The following is a description of a gene set: studied in species Mus musculus Mouse Gene Set: GOMF_UBIQUITIN_LIKE_PROTEIN_LIGASE_BINDING Binding to a ubiquitin-like protein ligase, such as ubiquitin-ligase., and this is the list of marker genes: Dnm1l (NCBI Gene Id 74006), Srprb, Xbp1, Hspa8, Pcbp2, Nfkbia, Erlin1, Sorbs1, Trp53, Ccdc50 (NCBI Gene Id 70600), Chek2 (checkpoint kinase 2), Abcb1b (NCBI Gene Id 18669), Ddrgk1, Trim28, Stat1, Bag6, Cul3, Kcnq3, Tlr3, Dio2, Magea10, Usp13, Cebpb, Stub1, Ube2j1, Zfp746, Smg5, Pink1, Usp25, Pa2g4, Fbxo7, Prdx6, Ralb (NCBI Gene Id 80581), Smc6, Wrap53, Aup1, Rnf40, Dtx3l, Hspa1b, Ski, Nedd8, Smad5, Tank (NCBI Gene Id 97021), Faf2, Atxn3, Jak1 (NCBI Gene Id 319959), Syt11, Egr2, Limk1, Cul5, Tcp1, Foxo1, Trib2, Smad3, Tpi1, Grk2, Ptk2b, Prkacb, H13, Rangap1, Hgs, Traf1, Trib1, Arih1, H2bc23, Ube2c, Trip4, Pax6, Det1, Ubash3b, Jun, Ankra2, Ubc, Ltbr, Ube2l3, Ptprn (NCBI Gene Id 19275), Tsg101, Nploc4, Slc25a5, Ambra1, Spop, Magea5, Rala, Brca1, Ggn, Rb1 (NCBI Gene Id 19645), Scn5a, Trib3, Ube2w, Laptm4b, Abcb1a, Bcl10, Cul7, Myc, Pias4, Vcl, Casc3, Rpl11, Traf4, Casp8, Hsp90ab1, Usp9x, Sipa1l1, Tdpoz2, Rps27a, Ubb, Erbb2, Uchl1, Rpl23, Pml, Pdlim2, Parp1, Gabarapl1, Rigi, Prr7, Tdpoz5, Fate1, Ccnb1-ps, Mdm2, Rpl5, Ube2a, Spopl, Cul2, Ywhae, Uqcrc1, Rad18, Sncaip, Spopfm2, Rhobtb3, Ube2g1, Bok, Prdx6b, Tubb5, Cxcr4, Mid1, Hif1a, Per3, Atp6v0c, Smad6, Rffl, Ifi204, Map1lc3a, Bag5, Rnf8, Cdk5rap3, Gpi1, Rnf31, Smad1, Sting1 (NCBI Gene Id 72512), Sh3kbp1 (NCBI Gene Id 80469), Becn1, Uba52, Ndufs2, Pias2, Rnf186, Rbx1-ps, Cacul1, Pias1, Sqstm1, Cdkn1a, Smad2, Spopfm3, Fzd8, Arrdc1, Stat2, Tnfrsf14, Hsp90aa1, Magec2, Rnf20, Rbx1, Nfe2l2, Syk, Vcp, Usp2, Prkar2b, Wbp1l, Cul9, Polr2a, Prkn, Hspa9, Kdm4a, Axin1, Hapstr1, Arrb2, Aurka, Dbt, Cul4b, Tdpoz4, Egfr, Snx9, Slf1, Sumo1, Fancl, Traf5, Cct2, Bag4, Dlg3, Lrpprc, Nlk, Elob, Xrcc5, Tnk2, Tnfrsf1b, Ubxn1, Cacybp, Parp9, Tmbim6, Cul4a, Hspa5, Fbxw7, Magea4 (MAGE family member A4), Ckb, Bid, Pik3r1, Otub1, Cdkn1b, Magea2, Arrb1, Gabarap, Gpr37, Fzd6, Sumo2, Aicda, Eif4e2, Smad7, Trim37, Gsk3b, Fau, Scamp3, Stx8, Traf3, Clu, Map3k7, Nae1, Moap1, Tdpoz1, Tuba1b, Prr5l, Ube2t, Blzf1 (basic leucine zipper nuclear factor 1), Pacrg, Prkar1a, Abi2, Bcl2, Mfhas1, Dnajb2, Lyn, Rpa2, Cbs, Ikbkg, Actn4, Ppargc1a, Patz1, Mc1r, Dnaja1, Rela, Grik2, Bag1, Hspd1 (NCBI Gene Id 15510), Per1, Magea3, Gm715, Ube2k, Txnip, Cul1, Hdac6, Ube2j2, Mfn2, Hspa1l, Glmn, Flt3, Itch, Sumo3, Myod1, Yod1, Tollip, Apbb1, Ngfr (nerve growth factor receptor (TNFR superfamily, member 16)), Erlin2, Slc22a18, Rnf34, Ube2n, Erbb3, Ifi205, Dazap2, Washc1, Fzd4, Fzd5, Mul1, Shprh, Tdpoz9, Triobp, Ripk1, H2bc9, Crk, Ccnb1, Jkamp, Derl1, Cd40, Mc4r, Herc2, Isg15, Actg1, Wfs1, Prkar2a, Pou5f1, Ptpn22, Hltf, Psma3, Ubxn7, Rraga, Dtx1, Laptm5, Prkaca, Fhit, Hspbp1, H2bc24, Daxx, Asb4, Calr, Stam, Acvr1b, Hspa1a, Nek6, Tgfbr1, Kcnh2, Traf2, Rtn4, Apc, Ikbke, Usp19, Ifi211, Anapc2, Map1lc3b, Slf2, Psmd1, Caml, Gabarapl2, Ctnnb1 (NCBI Gene Id 12387, catenin beta 1), Nkd2, Ube2b, Spart, Faf1, Ywhaz, Axin2, Tdpoz3, Ubox5, Tdpoz8